Given this list of marker genes FMNL2, PCDH19 (protocadherin 19), LSM12, FGF7, ZRANB3, LIN7A, RBSN, ZEB2, ZFP28, MED12, CBX4, RNF19A, TPGS2 (tubulin polyglutamylase complex subunit 2), RPF2, RIC1, PI4K2B, GAB1, GPM6A, PDS5B, MCFD2, UBE2V1 (NCBI Gene Id 7335), RTF1, SKA2, NR5A2, MSR1, HDAC9, RBM26, ARL5A, RALGAPA1, JUN, PCNX4, FUT9, FUBP1, FRMD6, DNAJB14, TBX18, PTPN12, HMBOX1, BDKRB2, USF3, RORA, BTBD3, NR4A2, EGLN1, TRA2B, TET1, MPRIP, WBP4, MAP3K1, TOX, CECR2, TRPC3, ABHD5, HYCC2, CDK17, PRRC2C, PDE4B, GOLPH3, KHDRBS2, NKD1, SLC35F1, ELK3, RECK, EP300, LUC7L3, ZFHX4, MID1, RNF166 (NCBI Gene Id 115992), KLHL5, PROX1 (prospero homeobox 1), SULF1, CCDC152, PHC3, USP38, TPK1, B3GNT2, DCX (doublecortin), RANBP3L, CTNNA3, BICD2, PCDHGA11, ELOVL6, DESI1, GPR26, THUMPD3, BRWD3 (bromodomain and WD repeat domain containing 3), SPRY4, PSMD12, FOXN2, ADGRF5, TMEM47, ACYP2, LTN1, TXNRD3, PTS, PEDS1-UBE2V1, SLC6A1, ANKRD40, ATXN7, RSL24D1, SLC14A1, PHACTR3, NOTCH1, MGAT3, CADM2, ZFX, AFF4, TMEM185B, PRDM1, LRCH2, ING2, MAP4K3, ZNF330, PPP1R18, RIPOR3, CASK (NCBI Gene Id 8573), OGFRL1, NUP58, OSBPL1A, RPS6KB1, BCORL1, THAP1, NIPBL, MST1L, SLC24A1, MEI4, ABL1, MOB4, ZNF592, BAG4 (NCBI Gene Id 9530), NF1 (NCBI Gene Id 646021), PHF21B, USP9X, AP1S2, PGM2L1, IL5, ZEB1, PCF11, MOCS1, CPEB3, MMD, RBBP4, TENT2, FAM13C (NCBI Gene Id 220965), RALBP1, ZSCAN29, PARP8, PTPN21, SRSF1, ABHD3, PARPBP, PRTG, CFL2, TTF2, PLOD2, PRR23A, PPP1R9A, GTPBP10, WASF1, SLC10A7, DEFB118, FUT4, PI4KB, BRMS1L (NCBI Gene Id 84312), KISS1R, TFAP2A, ANKRD34B, ZFTA, FSD1L, SPRTN, AKT1, KBTBD6, ELMOD1, OSBP, ARK2N, FOXF1, SCN5A, TET2, OSTM1, PYGO1, TDG, TRPC5, RBM15, TPCN1, FBXO38, NAP1L3, HIPK3, MPPED1, ABRA, ZNF770, RBM46, ATP11C, CDC27, CPXCR1, PDK2, MINDY2, EID2B, VGLL3, MYT1, MMAA, MYO19, SETD9, SRSF6, PRICKLE1, TMEM68, AKT3, RMI1, SALL3, DEPDC1B, PPM1A, DUSP1, ATP11A, MIPOL1, QKI, GCSH, C2orf88, RAP1A, MARCHF6, UGT2A3, SEPHS1, SCAI, ZNF711, EPC2, RASA2, FLRT3, XKR8, CTTNBP2NL, SIRT1, ARL2BP, DNAJB9, TOPBP1, ATP11B, DLC1, ELK4, FAM114A1, DEK, UBE3C, MAP2, SNX30, RAB11FIP2, GPN3, ALDH1A1 (NCBI Gene Id 96075), here is a description of the gene set: studied in species Homo sapiens from publication Chen Y, Wang X (PMID 31504780) Genes predicted to be targets of miRBase v22 microRNA hsa-miR-8084 in miRDB v6.0 with MirTarget v4 prediction scores > 80 (high confidence targets). Human Gene Set: MIR8084